The following is a description of a gene set: A process in which force is generated within muscle tissue, resulting in a change in muscle geometry. Force generation involves a chemo-mechanical energy conversion step that is carried out by the actin/myosin complex activity, which generates force through ATP hydrolysis. studied in species Homo sapiens Human Gene Set: GOBP_MUSCLE_CONTRACTION, and this is the list of marker genes: MIR21, EDNRA, STRIT1 (small transmembrane regulator of ion transport 1), PIK3CG, GUCY1A1, P2RX1, ITGA2, KCNJ5, SMAD7, DMPK, LTB4R, P2RX3, CKMT2, CHRNB2, SULF2, ROCK1, MYL9, TPM2, APBB2, CLCN1, TMOD3, MYH6, GNAO1, GPER1, RCSD1, KCNIP1, ADRA1B, CACNA2D1, CACNB1, CSRP3, REM1, GAA, SCN8A, KCNE3, RNF207, TCAP, STAC3, TRPV1, GRIP2, TACR1, KCNN2, ATP1A2, GAMT, STAC, NKX2-5, MYH4, NPNT, JPH3, BDKRB2, SLC8A3, MAP2K3 (mitogen-activated protein kinase kinase 3), SSPN, ANXA6 (annexin A6), PVALEF, EDN3, TNNT1, CERT1, DOCK5, GHRL, SCN1B, CALD1, EMD, TMOD2, LARGE1, ADA, TNNI3K, DES, KCNJ2, CHRND, TNNI3 (troponin I3, cardiac type), TPM3, NEUROG1, KCND2, PROK2, EDN1, ADRA2A, MYL6, MIR143, JPH4, CHRNA3, ATP8A2, ANK2, P2RX2, MYL2, SCN2B, DCANP1 (NCBI Gene Id 140947), CHRNG, PKP2, ZDHHC21, MIR448, SCN2A, UTRN, ADORA1, GJC1, SCN5A, ADRA2B, RGS2, GATA4, EEF2, DRD1, JSRP1, ADORA2B, HTR7, TACR3, ACE2, CACNA1C, DAPK3, GPD1L, PGAM2, PDE4B (NCBI Gene Id 5142), CLIC2, JUP, ATP2B4, KCNQ1, ANKRD2, JPH2, KCNE5, KCNIP2 (potassium voltage-gated channel interacting protein 2), SLC9A1, NUP155, GLRA1, KCNE1, STUB1, MIR328, KIT, ABAT, CHRNB1, MYL6B, ADGRD1, FGF13, SPX, MYL11, ACTA2, CAV3, MIR153-1, MIR145, GALR2, KCNE4, ATP1A1, CRYAB, SRI, SCN11A, NMUR1, GSTO1, SLMAP, MYH2, STAC2, NMUR2, FLNA, APBB1 (NCBI Gene Id 322), GJA5, CALM3, KCNJ3, SMTN, TNNC2, ADRB2, TRDN, SUMO1, CAV1, KCNB2, MYL5, SCN4A, TRPV4 (NCBI Gene Id 8098), FKBP1B, SETD3, DTNA, SCN10A, SPHK1, MYBPH, CTNNA3, CALM1, TNNI2, ORMDL3, CACNA1G, TPCN2, SCN9A, PRKG1, KBTBD13, CHRNB4 (NCBI Gene Id 1143), ALDOA, MIR133A1, SCN3A, SCN3B, ATP2A2, SCNN1B, RAP1GDS1 (Rap1 GTPase-GDP dissociation stimulator 1), KCNE2, SRSF1, IRAG1, JPH1, TRPM4, CHGA, MYH14, TMOD1, PRKACA, MYH7B, HRC, RYR1, TMOD4, SGCD, RYR2, DDIT3, RYR3, ADRA2C, TNF, EDNRB, TIFAB, LMOD2, CHRM3, MYBPC3, VEGFB, GSN, MAP2K1, NPY2R, AKAP9, P2RX4, TACR2, STC1, MYOCD, TRIM63, EHD3, ASPH, PPP1R13L, DSC2, ROCK2, PTGER3, CASQ2, SCN4B, FXYD1, MYLK, ADCY10, MYH11, ARG2, ATP2A1, DOCK4, OXT, TMEM38A, SCN7A, RHOA, CASQ1, OXTR, UTS2, MIR30E, CTTN, PPP1R12B, TBX20, MKKS, SYNM, MYH8, EDN2, KCNMA1, HTR2B, ATP1B1, GRK2, MIR200C, ENO1 (NCBI Gene Id 81977), CNN1, SRF, TBX3 (NCBI Gene Id 91834), ARHGEF11, TMEM38B, MIR1-1, NOS1AP, SMAD5, ACTC1, GHSR, PLN, NDUFS6, TTN, DMD, NOS1, TPM1, KCNA1, SGCA, RANGRF, BBS2, SLC6A8, ACTA1, KLHL41, FGF12, PRKD1, TRPA1, KCND3, SNTB1, HSP90AA1, VPS54, SELENON, CHRNE (cholinergic receptor nicotinic epsilon subunit), HTR1D, UCN, PIK3C2A, ATP2B1, TNNT2, MYL1, HTR2A, SLC8A1, CCDC78, MYOM2, CACNB2, ACTN3, SMPX (NCBI Gene Id 23676), CHRNA1, DSG2, NEDD4L, KCNA5, CACNA1D, LMOD3, MAP2K6, CALM2, MTOR, MYLK2, KCNJ8, ZC3H12A, TNNC1, F2R, BMP10, MYH1 (NCBI Gene Id 4619), SCN1A, TNNI1 (NCBI Gene Id 7135), KCNH2, TBX2, DRD2, NPPA (natriuretic peptide A), MYOT, FKRP (fukutin related protein), MYH7, CAMK2D, CHRM2, MYOF, PDE4D, ABCC9, GDNF, C10orf71, TBXA2R, FKBP1A, CD38, MYL3, SOD1, CHUK, CACNG1, CACNA1H, DLG1, COMP, CACNA1S, HCN4, HOMER1, ADRA1A, TNNT3, MYH3, MYH13, CALCA, P2RX6, ARHGAP42, NMU, GSTM2, KCNJ12, DSP (NCBI Gene Id 202512), TPM4, GJA1, HSBP1, PIK3CA, LMOD1, MYL4, PABPN1, BIN1, SNTA1, SULF1, C12orf57